The following is a description of a gene set: Mouse Gene Set: GOBP_VESICLE_MEDIATED_TRANSPORT A cellular transport process in which transported substances are moved in membrane-bounded vesicles; transported substances are enclosed in the vesicle lumen or located in the vesicle membrane. The process begins with a step that directs a substance to the forming vesicle, and includes vesicle budding and coating. Vesicles are then targeted to, and fuse with, an acceptor membrane. studied in species Mus musculus, and this is the list of marker genes: Fpr2, Cd320, Rasgrp1, Igf1r, Trip11, Tmem115, Dnajc5, Tprg1l, Arrb2, Enpp2, Erp29, Rab31, Gpihbp1, Lman2, Rinl, Scn11a, Napa, Ildr1, Atp6v0e2, Nsg1, Arl5a, Mtm1, Cops5, Rab7, Fcgr2b, Pheta2, Lep, Sft2d2, Ramp1, Trappc4, Exoc7, Mdm2, Rab30, Mbl1, Lsr, Acsl3, Arl3, Atp6v1f, Atp6v1g2, Th, Scrib, Pacsin1, Arl5c, Abl2, Vps4b, Copg2, Peg10, Lyst, Fcho2, Laptm5, Neu3, Hnrnpk, Septin4, Scarb1, Olr1, Lgals9, Nos2, Usp46, Tgfbr2, Trappc5, Rhov, Bves, Sec22b, Lman1 (lectin, mannose-binding, 1), Wnt7a, Vav3, Tmed6, Dock1 (dedicator of cytokinesis 1), Asgr2, Pex5l (peroxisomal biogenesis factor 5-like), Rdx, Slc10a4, Bin2, Gata1, Intu, Cxadr, Vps16, Rab14, Alox15, Unc13a, Ins1, Rubcnl, Copb2, Btbd9, Abr, Dennd5a, Adra2a, Serpine1, Clip3, Cd163, Bsn (bassoon), Adora2b, Tmem167b, Snx17, Ncs1, Tnfaip2, Nckipsd, Tmed2, Mvb12a, Tmem87b, Lat, Sv2c, Zfyve16, Sphk1, Arhgdia, Il13ra2, Cacna1d, Hspg2, Chrna7, Rab11fip2 (NCBI Gene Id 74998), Pparg, Sag, Arf1, Amph, Scyl1, Cdx2, Ctbp1, Pla2g4e, Map2k1, Ube3a, Ncl, Prkd1, Sdcbp, Sptbn1, Kif5a, Fgb, Cog2, Pear1, Ankfy1, Gpr151, Dcx, Wnt5a, Fcgr4, Mgrn1, Hpca, Treml4 (NCBI Gene Id 75989), Nckap1l, Letmd1, Btbd8, Rab27a, Rab11b, Cux1, Exoc1, Amn (NCBI Gene Id 93835), Znrf2, Sirpb1a, Vps33b, Sv2b, Prkn, Cmtm6, Nsf, Dync1li1, Nedd4, Eqtn, Wdr72, Cask, Cd2ap, Epn2, Snx3, Nppc, Il15, H1f1, Bet1, Gak, Itgb1 (integrin beta 1 (fibronectin receptor beta)), Ap4m1, Arfip1, Tmem108, Hap1, Snph, Sec24d, Itgal, Ppp3cb, Wipf3 (NCBI Gene Id 330319), Ap5z1, Vps36, Tvp23a, Clec9a, Stx8, Rabgap1l, Pick1, Sec22c (SEC22 homolog C, vesicle trafficking protein), Cxcr2, Rimbp2, Foxf1, Rspo1, Timd6, Cnih4, Acap2, Adgrb1, Rabep1, Src, Cap1, Sele, Htr1d, Prg4, Spire1, Tmed11, Picalm, Ppfia3, Nlgn1, Lin7c, Surf4, Lrrtm1, Rab29, Pip5k1c (phosphatidylinositol-4-phosphate 5-kinase, type 1 gamma), Sh3bp4, Msr1, Il4, Fcgr3, Vps53, Mrc2, Dennd2a, Nedd4l, Atp2c1, Synj1, Prkar1b, Lilrb4b (leukocyte immunoglobulin-like receptor, subfamily B, member 4B), Unc13d, Rin1, Sftpd, P4hb, Rab25, Actn4, Golph3l, Rab34, Clasp2, Mtmr4, Elmo2, Ccr7, Ap1ar, Mapk10, Snx5 (sorting nexin 5), Hmmr, Tmem63b, Rufy4, Insig1, Ank3, Golga4, Heatr5b, Lgals3bp (lectin, galactoside-binding, soluble, 3 binding protein), Plscr1, Spry2 (sprouty RTK signaling antagonist 2), Entr1, Appl2, Gab2, Golga7, Anxa11, Ptpn1, Cd9, Ckap5, Ap4s1, Stab1, Tlr2, Fpr-rs6, Fcer1g, Neurl1b, Ehd4, Chmp4b, Ccr1l1, Mx2, Marchf2, Rab32, Ap1b1, Dennd1c, Snf8, Trex1, Vamp2, Trappc12, Tub, Spi1, Ins2, Fcer2a, Tbc1d10c, Exoc6, Exoc5, Add1, Map4k2 (mitogen-activated protein kinase kinase kinase kinase 2), Epn1, Zp3, Becn2, Wasf2, Rab38 (RAB38, member RAS oncogene family), Tbc1d14, Cnih1, Sar1a, Yif1a, Cyfip1, Lrrtm2, Eif2ak1, Dtx3l, Vcp, Ncf2, Atg14, Scrn1, Clnk, Evi5, Hps1, Vps54, Hras, Lgi3, Prickle1, Git2, Phaf1, Kif1c, Fshr, Cacna1e, Wipi1, Copa, Atp6v1b2, Napg (N-ethylmaleimide sensitive fusion protein attachment protein gamma), Dgkd, Ptgds, Tbc1d8b, Als2 (alsin Rho guanine nucleotide exchange factor), Syt13, Synrg, Sgsm2, Zp3r, Ap4b1, Mppe1, Stx18, Agap2, Pacsin2, Clasp1, Myo18a, Colec10, Reps2, Plekhm2, Vps33a, Mon2, Ap2s1, Orai1, Myo1g, Rab5a, Ankrd13a, Plekhf1, Ap3s1, Rhou, Klhl12, Dppa1, Elane, Vti1a, Septin1, Vps26c, Gcgr, Cd22, Rab3a, Brsk1, Rp2, Vldlr, Cxcr1, Snapin, Lman2l, Gpc3 (glypican 3), Lmbr1l, Myo19, Ahsg, Chmp2a, Gosr1, Lpar1, Itgb3, Rab27b, Rab36, Rap1a, Arl5b, Stard3, Josd1, Abca2, Sec13, Rab10, Bnip1, Copb1, Sytl4, Vapb, Siglecf, Cacna1a, Hook1, Trak1, Calcrl, Pik3cb, Laptm4b, Tex261, Stxbp5l, Npc1, Epg5, Stx1b, Gdi2, Lrp6, Rab26, Arap1, Arl4c, Ap3b1, Myo7a, Cyba, Arhgap21 (Rho GTPase activating protein 21), Rab17, Mapkapk2, Il1rapl1, Vps4a, Rab39b, Nsg2, Kif1a, Plcb3, Dennd1b (NCBI Gene Id 77060), Kdelr2, Tmem50a, Syt7, Ptx3, Golt1a, Atg5 (NCBI Gene Id 97669), Dvl1, Lamtor1, Sfrp4, Myo15a, Usp7, Rab1b, Lrrk2, Kif17, Kif3b, Cxcl16, Il13, Pgap1 (NCBI Gene Id 75976), Myo5c, Apoe, Actg1 (NCBI Gene Id 230535), Mapkapk3, Cacna1b, Sncg, Ccl21a, Stxbp2, Stxbp5, Tmed10-ps, Rab3c, Myh9, Syt8 (synaptotagmin VIII), Trf, Adm, Plpp3, Plek, Cnih2, Cep19, Creg1, Slc17a5, Lman1l, Ifng, Casp3, Ticam2, Rims1, Tbc1d10b, Appl1, Rbsn, Cbll1, Atg3, Kif5b, Snap29, Mia3, Stard3nl, Cope, Gas1, Cog8, Gsn, Nrxn1, Bicd1, Spon2, Vps26a, Cracr2a, Hck, Gulp1, Il2rb, Slc9b2, Ap1s1, Mtmr9, Macf1, Vps50, Fsip1, Wdr54, Tvp23b, Stbd1, Wdr11, Gria1, Sdf4, Csk, Grem1, Snca, Arl11, Lat2, Ahi1, Tamalin, Drd2, Smpd1, Mff, Pikfyve, Syt1, Stx1a, Cog4, Tmem167, Hmox1, Ankrd13d, Lrp11, Xkr8, Myo1c (NCBI Gene Id 97728), Sec22a (NCBI Gene Id 69021), Stxbp1, Mertk, Epb41l1, Stxbp6, Sec24b (NCBI Gene Id 99683), Marchf3, Trappc1, Usp20, Nbea, Il4ra, Ndp, Efr3a, Atp5f1b, Pls3, Ptger3, Washc3, Vipas39, Rab33b, Slc66a2, Sh3glb2, Lipa, Pitpnb, Cspg5, Golt1b, Kcnq3, Pdcd6ip, Exoc3l, Arfgap2, Chmp2b, Camk1d, Cd160, Snx7, Atp6v1c1, Ccl3, Caly, Rab40c, Ackr3, Npy, Tmed5, Sec16b, Cog1, Lin7a, Efnb2, Rims2, Ube2o, Knl1, Mapk3, Smcr8, Diaph1, Atp9b, Nrg1, Sdc1, Rabep2, Kdelr3, Rara, Sgip1, Exph5, Washc4, Synj2bp, Map2k2, Arfgap1, Cplx4, Ap3m2, Mtmr2, Trip10, Opa1, Slc18a3, Rhob, Gbf1, Sytl2, Dctn1, Lyve1, Arfrp1, Preb, Grip1, Trim27, Syt5, Milr1, Stx4a, Rab3d, Pla2g6, Vps35, Rab2b, Amn1, Sox30, Cttn, Siglece, Ackr4 (NCBI Gene Id 252837), Trim9, Rab21, Lilrb4a, Plaa, Sv2a, C2cd6, Rab5c, Fmr1, Aktip, Vps8, Atad1, Myo5a (NCBI Gene Id 57374), Cd63, Syt2, Itgb2, Grk3, Timd5, Rab3b, Rock1, Erc1, Atp6v0a4, Lypd10 (NCBI Gene Id 381977), Slc11a1, Sh3gl2, Chmp4c, Ap1s3, Dnm2, Tpcn2, Arhgap25, Apln, Rac2, Calr, Rims3, Arrb1, Pef1, Klrh1, Kcnh1, Ncam1, Calm2, Yipf7, Vamp4, Clcn3, Heatr5a (NCBI Gene Id 320487), Susd4, Rab2a, Arfgef2, Slitrk1, Golga5, Esyt2, Ppt1, Npy1r, Cog6, Rin2, Cd302, Drd3, Trappc13, Snx9 (NCBI Gene Id 66616), Myd88, Lyplal1, Trappc2l, Wasl, Rtn3, Nostrin (nitric oxide synthase trafficker), Slc30a6, Mkln1, Rilp, Pik3ca, Steep1, Mfsd2a, Vta1, Rabgef1, Yipf2, Timd4, Rnf220, Exoc8, Itga2, Axl, Il15ra, Sh3gl1, Arf2, Arf3, Brsk2, Exoc3, Lrp12, Itgav, Park7, Xkr4, Sycn, Trim72, Akap5, Rab9b, Fcmr, Srpx, Sytl5, Rab42, Krt18, P2rx7, Siglech, Tmem87a, Myo1h, Rab11fip4, Pot1b, Cebpe, Arhgap27, Fcnb, Yipf5, Pou5f1, Ap2m1, Sgsm3, Tfg, Clec4f, Sec31a, Dennd3 (DENN domain containing 3), Actn2, Vps11, Flna, Cacfd1, Git1, Sptbn2 (spectrin beta, non-erythrocytic 2), Wdr91, Rcsd1, Lrp1, Snx19, Rala, Atp6v0c, Itsn1, Cdk5r2, Ank2, Bloc1s6, Sec16a, Cadps, Atp6v1a, Cav1, Pcsk9, Scfd2, Plekha3, Dop1b, Grin2a, Zfyve9, Tfrc, Fkbp15, Cltb, Dnm1, Nr1h2, Syt15, Cyth3, Cplane2, Vps13b, Stx2 (syntaxin 2), Grk4, Snx2, Slamf1, Slc10a7, Megf6, Vti1b, Grxcr1, Rab43, Rgp1, Ankrd27 (NCBI Gene Id 352948, ankyrin repeat domain 27), Bin1, Notch1, Ramp3, Nrbp1, Kif16b, Gnao1, Dll1, Trappc3, Tmem50b, Lrp8, Vps39, Pip4p2, Slc32a1, Pllp, Prom2, Doc2g, Hyal3, Fpr-rs4, Lepr, Lmbrd1, Stx6, Pla2r1, Cacna1c, Stx19, Llgl1, Rac1, P2rx1, Canx, Fcer1a (Fc receptor, IgE, high affinity I, alpha polypeptide), Nfix, Plekhj1, Caml, Reps1 (NCBI Gene Id 19707), Vamp9, Kcnb1, Itga4, Smpd3, Enthd1, Pik3c3, Mrgprx2, Enpp1, Lrp2, Cadps2, Cplx2, Pten, Actb, Vtn, Atp6v1g3, Myo7b, Pkdcc, Cd36, Atp6v1d, Scarb2, Arl4a, Dnajc6, Txlna, Bcr, Magi2, Cideb, Fcgr1, Tbc1d4, Ank1, Eef2k, Fes, Grk2, Uso1, Plxnb2, Rab44, Ighe, Cblb, Ldlrad3, Arf5, Pld4, Fgg, Coro7, Apoc2l, Arl6, Ptgdr, Otof, Cacna1i, Hip1, Sec24c, Stx5a, Tbc1d20, Vav1 (vav 1 oncogene), Ap2b1, Ap3b2, Vps25, Gprasp1, Tmem175, Lmtk2, Snx4, Tmcc1, Pram1, Rasef, Cftr, Rufy1, Epn3, Mbl2, Ighg1, Hmgb1, Atp6ap2, Ezr, 5730455P16Rik, Myo6, Cd209b, Rab20, Pld1, Stx17, Htt, Clec16a, Fgf14, Cd151, P2rx2, Dpysl2, S100a10, Myh10, Drd4, Sirpa, Yipf1, Stx11, Psen1, Epha3, Vps29, Vegfa, Timd2, Trappc6a, Arl4d, Apoc3, Adora3, Fpr-rs7, Mfge8, Atp8a1, Dgkq, Tmed7 (NCBI Gene Id 76112), Stxbp3, Mia2 (MIA SH3 domain ER export factor 2), Cryba1, Lrp5, Cd300a, Crhbp, P2ry2, Myo5b, Pip4k2a, Atp6v1g1, Bicd2, Calm1, Atp2a2, Arl1, Ap4e1, Tbc1d10a, Ankrd50, Tcp11, Borcs7, Syt11, Cd300lf, Tac4, Jmjd6, Sec24a, Yipf4 (Yip1 domain family, member 4), Chmp5, Becn1, Arr3, Tspan18, Rab35, Rapgef4, Cacna1g, Mst1r, Ddc, Pard3, Lrrc7, Plekhf2, Snx16, Il10ra, Alms1, Slc17a8, Arhgap8, Syngr1 (NCBI Gene Id 98000), Tnk2, Syndig1, Rnf139, Tbc1d2b, Ric1, Trem2, Mcoln1, Napb, Coro1a, Csnk1g3, Rap1gap, Thbs1, Clec7a, Ly75, Snx18, Prkci, Tgm2, Tph1, Trim23, Ergic3, Lbp, Vps51, Plcg2, Cnst, Arpc3, Slc17a6, Arf6 (NCBI Gene Id 11845), Sec23b, Cd44, Syt9, Kif13a, Syde1, Scamp5, Ap5s1, Snap47, Chmp1b, Sdc4, 4933434E20Rik, Tlr4, Ppp3cc, Ptafr, Tom1, Mib1, Gsg1l, Nme1, Aif1 (allograft inflammatory factor 1), Tbc1d23, Syk, Colec11, Was (Wiskott-Aldrich syndrome), Syn1, Mlc1, Ywhaz, Myo1f, Gdi1, Vps35l, Rab8b, Carmil1, Pheta1 (PH domain containing endocytic trafficking adaptor 1), Insr, Rhobtb3, Gnai3, Itsn2, Tm9sf4, Lrba, Tspan7 (NCBI Gene Id 97622), Tmed1, Syt6, Septin8, Cacnb4, Tg, Washc2, Pik3c2a, Syngr2, Cntn2, Chic2, Arhgap17, Cav2, Rhoj, Ophn1, Mon1b, Tfr2, Snx10 (NCBI Gene Id 71982), Lmf1, Vac14, Chm, Eipr1, Micall1, Anxa8, Dlg4, Washc5, Apoa1, Cfp, Ap3s2, Megf11, Adrb2, Fmn2, Hook2, Abca7, Apoc1 (NCBI Gene Id 11812), Itch, Rit2, Bltp1, D6Wsu163e, Naglu, Kxd1, Atp6v0a1, Endou, Pla2g4a, Gcc2, Trarg1, Vps26b, Gpr107, Ap1s2, Cd209a, Inppl1, Ramp2, Flot1, Myo1e, Colec12, Dnajc13, Dennd10, Rer1, Llgl2, Cplx3, Hook3, Yif1b, Ehbp1, Cog5, AU040320, Vps45, C3, Egfr, Havcr1, Rph3al, Gripap1, Clta, Tmem79, Cd14, Slc17a7, Dkk1, Kctd9, Znrf1, Kif3a, Plk2, Vps9d1, Gga2, Clu, Bloc1s2, Rab11fip3 (RAB11 family interacting protein 3 (class II)), Cacna1h, Vamp3, Vps18, Pacsin3, Unc13c, Grb2 (NCBI Gene Id 14784), Steap3, Cd177, Lrp10, Cd81, Mon1a, Myo1a, Fnbp1, Psg22, Ptk2, Ptpn5, P2ry1, Rnasek, Eps15, Nlgn2, Wnt3a, Gnai2, Ralb, Ero1b, C9orf72, Ifitm3, Stx3, Ap5b1, Apoc2, Optn, Necap1, Doc2a, Lypd11, Prkca, Ralbp1, Atp6v1b1, Rab11a, Ache, Scarf2, Spast, Sh3kbp1, Lgals3, Myo1d, Ap1g1, Nbas, Irf8, Ldlr, Eea1, Atp6v1e1, Ap2a1, Cdk5r1, Atp6ap1, Ndrg4, Lin7b, Pla2g3, Leprotl1, Sort1, Sytl3, Ager, Rab22a, Snap91, Gp2, Prkaca, Mrc1, Ackr2, Lyn, Cd84, Rims4, Gria2, Hyou1, Trappc6b, Trappc11, Ano6, Lamp1, Pdcd6, Ctnnb1, Sar1b, Cd209d, Scarf1, Sncb, Fhip1b, Siglec1, Pigr, Syt10, Ehd3, Zdhhc2, Xkr6, Csnk1e, Ms4a2, Ap1g2, Unc119, Fam91a1, Hip1r, Trappc3l, Prtn3, P2ry4, Megf10, Ntf3, Syt4, Cbl, Trappc9, Arhgap44, Apoa2, Ppp3r1, Cln5, Ush1g, Wasf1, Rint1 (RAD50 interactor 1), Vamp1, Ptprc, Slc48a1, Nkd2, Rubcn, Trappc2b, Ehd2, Uvrag, Rab1a, Slc18a2, Rph3a, Chp1, Mapk15, Ccr1, Rab12, Hamp, Nr4a3, Bltp3b, Lrsam1, Chmp1a, Il2rg, Rabif, Gga1, Ccz1, Cd47, Doc2b, Usp6nl, Hps4, Ap3m1, Dnm3, C4bp, Commd1, Syt12, Atp9a, Inpp5f, Bloc1s5, Coro1c, Snx30, Hfe, Anxa1, Rhoq, Ap5m1, Hspa8, Rest, Ccl2, Sytl1, Mtmr6, Copz1, Bin3, Septin7, Entrep1, Xkr7, Pla2g5, Ston2, Cltrn, Tbc1d24, Use1, Dtnbp1, Rab4b (RAB4B, member RAS oncogene family), Kcnq2, Lypla1, Chmp3, Csnk1g1, Micall2, Scfd1, Eps15l1, Cog7, Chga, Kcnn4, Tgfbrap1, Ephb2, Ccl19, Dop1a, Copg1, Mesd, Cnih3, Scyl2, Ccdc22, Scamp1, Pip4k2b, Exoc3l4, Dab2, Tulp1, Trappc10, Dennd1a, Tgfb1, Cul3 (NCBI Gene Id 98674), Rangrf, Tusc2, Smap1, Zfyve27, Rab7b, Elmo3, Anxa2, Washc1, Anxa3, Snx8, Rab11fip5, Exoc2, Ctbp2, Slc4a8, Itgam, Ergic1, Cdk16, Abca1, Kdelr1, Vapa, Rab15, Rab39 (RAB39, member RAS oncogene family), Bmp2k, Mctp1, Slc1a1, Dnm1l, Prrt2, Stx12, Rab6b, Trak2, Sft2d1, Dipk2a, Kif1b, Bbs2, Fcho1, Pecam1, Htr1b, Gpr15lg (G protein coupled receptor 15 ligand), Spg11, Tmed4, Clint1, Ppfia2, Elmo1, Pstpip1, Fnbp1l, Aplnr, Synj2, Atp6v0d1, Ighg2b, Abl1, Gata2, Mical1, Cltc, Fchsd2, Icam5, Lrpap1, Pcdhga3, Syp, Sacm1l, Def6, Wdr44, Rab40b, Rab4a, Cd300lg, Myo1b, Fpr-rs3, Scap, Clstn1, Pycard, Atxn2, Tsg101, Rab11fip1, Wdr41, Fuz, Tbc1d17, Chml, Spag9, Bcap29, Lyar, Ccdc91, Vps52, Mylk, Nkg7, Pik3r4, Cep83, Slc9a6, Ssc5d, Gabarapl2, Als2cl, Stx16, F2rl1, Capn2, Prepl, Nf2, Arhgap1, Cav3, Mbtps1, Cnn2, Slc9a3, Hgs (NCBI Gene Id 21921), Pcdh17, Vamp5, Cog3, Mrgprb1, Marco, Syt3, Hpse, Arc, Fgr, Slc18a1, Sh3gl3 (NCBI Gene Id 20408), Ston1, Mex3b, Scara5, Aak1, Creb3l2, Nod2, Cdh2, Usp33, C2cd5, Snx27, Trappc2, Diaph3, Clcn5, Egf, Ptprj, Ap1m2, Pi4k2a, Tyro3, Ighm, Pink1, Ift27, Yipf6 (NCBI Gene Id 77929), Ap1m1 (adaptor-related protein complex AP-1, mu subunit 1), Bcl2l1, Pdpk1, Stab2, Dmbt1, Fbxl20, Snx32, Neurl3, Cdc42se2, Snap25, Rabggta, Vps28, Tor1a, Rab8a, Ykt6, Vsnl1, Ergic2, Prss12, Atp13a2, Chmp7, Cln3, Rab6a (NCBI Gene Id 19346), Ccdc93, Dpy30, Snx1, Rapgef1, Ubxn6, Crhr1 (corticotropin releasing hormone receptor 1), Zfpl1, Clcn2, Cd209e, Cplx1, Unc13b, Nlrp5, Mcfd2, Ccl5, Septin5, Rab5b, Nppa, Syn2, Baiap3, Syn3, Mapk8ip3, Ier3ip1, Abca12, Tyrobp, Ptpn23, Sec31b, Pros1, Snx12, Tbc1d5, Rab3gap1, Grik5, Wdr81, Ceacam1, Emp2, Pfn2, Lrp1b, Sorl1, Rack1, Tmed10, Rab37, Rnf216, Apela, Cdh13, Steap2, Atg7, Hamp2, Grn, Tsc2, Osbpl2, Ap2a2, Camk2a, Angpt1, Rabggtb, Fbxo45, Asgr1, Rab9, Gas6, Dbnl, Gas7, Arfgap3, Arcn1, Snx31 (NCBI Gene Id 66696), Cbarp, Stap1, Csnk1g2, Exoc3l2, Samd9l, Syngr3, B2m, Uevld, Copz2, Sphk2, Srcin1, Kit, Exoc4 (exocyst complex component 4), Slc30a8, Braf, Spire2, Itgb2l, Magel2, Syt17, Cdc42, Ceacam2, Klhl20, Dysf (dysferlin), Chmp1b2, Sftpa1, App, Grp, Zw10, Ncf4, Plekhm1, Sft2d3, Tmed9, Chmp6, Ccdc32 (NCBI Gene Id 269336), Abca13, Snap23, Pik3cg, Rap1b, Tbc1d21, Cd24a, Cdk5, Btk, Bet1l, Sirt2, Vps41, Exoc6b, Blzf1, Fga, Pak1, Bcap31, Golga2, Nr1h3 (nuclear receptor subfamily 1, group H, member 3), Erc2, Stam, Shh, Csnk1d, Sod1, Rab13, Cdc42se1, Msn, Necap2, Golph3, Mical3, Adipoq, Tafa4, Grip2, Dock2, Gga3, Ankrd13b, Lrp4, Arl8b, Prkcg, Kcnc3, Ldlrap1, Stx7, Rin3, Ehd1, Leprot, Iqsec1, Prkcb, Mapk8ip1, Nlgn3, Necab2, Ulk1, Lyset, Ap3d1, Slc2a4, Mapk1, Arl14, Ncdn, Bloc1s1, Vamp8, Pld2, Ccr2, C2, Ppp3ca, Apobr, Sorcs1, Sec23a, Aplp1, Sys1 (NCBI Gene Id 98891), Atp6v1h, Rnf126, Ccl8, Jagn1, Snx33 (NCBI Gene Id 235406), Arhgap12, Ubqln2 (ubiquilin 2), Pclo, Sh3bp1, Whamm, Gapvd1 (NCBI Gene Id 99322), Cubn, Ghr, Snx6, P2ry6, Prkaa1, Calm3, Arf4, Bbs1, Numb, Tmed3, Sh3glb1, Gosr2